Given this list of marker genes Gabrb3, Rab44, Gabrb2, Hrh1, Cracr2a, Gabra1, Drd4, Gabrg2, Drd3, Drd2, Diaph1, Gabrb1, here is a description of the gene set: Any process that results in a change in state or activity of a cell or an organism (in terms of movement, secretion, enzyme production, gene expression, etc.) as a result of a histamine stimulus. Histamine, the biogenic amine 2-(1H-imidazol-4-yl)ethanamine, is involved in local immune responses as well as regulating physiological function in the gut and acting as a neurotransmitter. species: Mus musculus Mouse Gene Set: GOBP_RESPONSE_TO_HISTAMINE